Given this list of marker genes LIMA1, SMOC1, FIBIN, FGF12, PTGDS, GPR17, SLC1A1, PGRMC1, HES6, LHFPL3, DLL1, ASCL1, MSMO1, DHCR7, BCAS1, OLIG2, ACAT2, SCRG1, BCAN, SERINC5, TUBB4A, PACC1, PLPPR1, SCD5, RGR (retinal G protein coupled receptor), SOX8, CNTN1, PSAT1 (phosphoserine aminotransferase 1), LMF1, CA10, P2RX7, DLL3, PLP1, NKAIN4, TNR, SIRT2, THY1, SGK1, ANGPTL2, RTKN, NEU4, MPZL1, APOD, CNP, OMG (oligodendrocyte myelin glycoprotein), RAB33A, TNFRSF21, OLIG1, FDFT1, PDGFRA, here is a description of the gene set: In this study, an extensive analysis was conducted to define meta-programs (MPs) capturing intra-tumor heterogeneity across a spectrum of tumor types. The approach utilized non-negative matrix factorization (NMF) to analyze each cell type separately within individual tumor samples. This involved the analysis of malignant cells, macrophages, fibroblasts, endothelial cells, epithelial cells, T-cells, and B-cells. NMF was executed with varying parameter values (K=4, 5, 6, 7, 8, 9), thereby generating 39 programs for each cell type per sample. Each NMF program was summarized by the top genes based on NMF coefficients.\nRobust MPs were then delineated for each cell type using a set of stringent criteria, including recurrence within the same tumor, similarity to programs in other tumors, and non-redundancy within a tumor. Subsequently, these robust NMF programs were clustered (per cell type) based on Jaccard similarity, leading to the identification of MPs associated with each cell type.\nTo enhance the quality of the MPs, a refinement steps were undertaken, involving the removal of MPs suspected of reflecting low-quality data (with an overrepresentation of ribosomal proteins or mitochondrial-encoded genes), single-study inclusion, or similarity to miss-annotated cell types. from publication Gavish A, Tyler M, Greenwald AC, Hoefflin R, Simkin D, Tschernichovsky R, Galili Darnell N, Somech E, Barbolin C, Antman T, Kovarsky D, Barrett T, Gonzalez Castro LN, Halder D, Chanoch-Myers R, Laffy J, Mints M, Wider A, Tal R, Spitzer A, Hara T, Raitses-Gurevich M, Stossel C, Golan T, Tirosh A, Suvà ML, Puram SV, Tirosh I (PMID 37258682) studied in species Homo sapiens Human Gene Set: GAVISH_3CA_MALIGNANT_METAPROGRAM_27_OLIGO_PROGENITOR Genes upregulated in subsets of cells of a given type within various tumors